The following is a description of a gene set: Mouse Gene Set: GOBP_ESTROUS_CYCLE studied in species Mus musculus A type of ovulation cycle, which occurs in most mammalian therian females, where the endometrium is resorbed if pregnancy does not occur., and this is the list of marker genes: Has2, Cckbr, Hspa8, Igf1r, Oxtr, Cyp1b1, Pcna, Erbb2, Ptn, Has1, Egr1, Mdk, Adnp, Slc26a6, Esr2, Enpp2, Ncoa1